Given this list of marker genes Clip2, Zfp804a, Map1a, Drd4, Bag2, here is a description of the gene set: Mouse Gene Set: GOCC_DENDRITIC_MICROTUBULE species: Mus musculus Any microtubule in a dendrite, a neuron projection.